Given this list of marker genes MRGPRD, AGT, MAS1 (MAS1 proto-oncogene, G protein-coupled receptor), AGTR1, AGTR2, SERPINF2, RHOA, here is a description of the gene set: The renal process that modulates the force with which blood travels through the circulatory system, by impeding blood flow through the peripheral vasculature. Human Gene Set: GOBP_RENAL_CONTROL_OF_PERIPHERAL_VASCULAR_RESISTANCE_INVOLVED_IN_REGULATION_OF_SYSTEMIC_ARTERIAL_BLOOD_PRESSURE species: Homo sapiens